The following is a description of a gene set: Pancreatic adenocarcinoma pathway species: Homo sapiens Human Gene Set: WP_PANCREATIC_ADENOCARCINOMA_PATHWAY, and this is the list of marker genes: BUB1B-PAK6, JAK1, TP53, BCL2L1, TGFB3, MAP2K1, PIK3CA, RAC2, DUSP6, RAD51, CDK4, EGFR, E2F2, MAPK9, CASP9, MAPK3, RALGDS, PAK6, CCND1, RIPK4, RALBP1, RELA, PIK3R2, BRAF, PIK3CB, BAK1, MAP2K2, BAX, RB1, AKT2, AKT3, PAK3, TGFA, SMAD2, IKBKG, STAT3, RPS6KB1, RALB, PAK5, CDC42, ARAF, E2F1, RHOA, CDKN1A, MAPK8, RAC3, PIK3R1, TGFBR2, RAC1, RALA, MAPK10 (NCBI Gene Id 5602), EGF, RAF1, CHUK (component of inhibitor of nuclear factor kappa B kinase complex), E2F3, MTOR, PEBP1, SMAD3, CDKN2A, PAK2, ARHGEF6, PAK1, VEGFA, STAT1, DDB2, SMAD4, TGFBR1, NFKB1, TIAM1, PLD1, TGFB2, GADD45G, BRCA2, PIK3R3, BAD, PRKCD, KRAS, IKBKB, ERBB2, AKT1, POLK, GADD45A, PAK4, MAPK1, TGFB1, GADD45B, PIK3CD, CDK6, RPS6KB2